Given this list of marker genes Mecp2, Zbtb18, Exo5, Panx2, Mtrr, Rragb, 1700017N19Rik, Mex3c, Gigyf2, Eif4e3, Tfap2b, Anxa6, Gimap8, Cnot6l, Clec4a2, Zfp871, Atpaf1, Tmem33, Gorab, 3425401B19Rik, Slc10a1, Pias1, Rhoa, Mbnl2, Dync1li2, C87436, Capn6, Mpc2, Zmat3, Aak1, Yy2, Ccdc178, Golga4, Vegfa, Il1rap, Mfap3, Ranbp3l, Rab3gap1, Blmh, Cntn1, G3bp1, Rab12, Nup37, Ppfibp2, Mapkapk3, Trem3, Polr1f, Phf20, Zfp24, Dctn6, Scaf8, Klf9, Mal2, Jkamp (JNK1/MAPK8-associated membrane protein), Immt (inner membrane protein, mitochondrial), Btf3, Hibadh, Slc35a5, Spata6l, Gns, Grip1, Zfp804a, Map2, Sdk1, Tdrd5, Fut9, Cadm2, Tubgcp3, Magea10, Zfp148, Myl12a, Abhd3, Fsd1l, Tet2, Mtmr10, Eif4ebp2, Tanc2, Rimkla, Xirp2, Hsp90aa1, Ing2, Eola1, Lgr4, Sox2, Cry1, Pllp, 4930550C14Rik, Retreg3, Ranbp17, Ddx3x, Pank3, Zmat4, Tex2, Rag1, Shroom2, Esrrb, Lrrc28, Acer2, Slc4a10, Dhrs9, Ubr5, Arl15, Echdc1, Lipa, Rnf14, Fbxo48, Pate6, here is a description of the gene set: Genes predicted to be targets of miRBase v22 microRNA mmu_miR_361_5p in miRDB v6.0 with MirTarget v4 prediction scores > 80 (high confidence targets). species: Mus musculus Mouse Gene Set: MIR_361_5P from publication Chen Y, Wang X (PMID 31504780)